The following is a description of a gene set: Human Gene Set: KEGG_MEDICUS_REFERENCE_KERATAN_SULFATE_DEGRADATION Keratan sulfate degradation. Pathway ID: N00623. Pathway type: Reference. Pathway class: nt06012 Glycosaminoglycan degradation. species: Homo sapiens Pathway Definition from KEGG: KS -- GALNS >> GLB1 >> GNS >> HEXA/B -> G01391, and this is the list of marker genes: HEXA, GNS, GLB1, HEXB, GALNS